The following is a description of a gene set: Human Gene Set: GSE37605_TREG_VS_TCONV_C57BL6_FOXP3_IRES_GFP_UP The aim of this study was to quantify the impact of chimeric Foxp3-GFP protein on the Treg cell transcriptional program. from publication Darce J, Rudra D, Li L, Nishio J, Cipolletta D, Rudensky AY, Mathis D, Benoist C (PMID 22579475) Genes up-regulated in splenocytes from Foxp3-ires-GFP B6 mice: T reg (FOXP3+) versus T conv (FOXP3-). species: Homo sapiens, and this is the list of marker genes: CFAP100, TRIM63, DPP10, KRT40, CRELD1, ACSBG1, FOXI3, P2RX5, CHRNG, CILP (NCBI Gene Id 8483), HAND1 (heart and neural crest derivatives expressed 1), NALF1, FTMT (NCBI Gene Id 94033), MBOAT4, HMG20B, FZD5, KRT33A, ATP2B3, SLC25A42, NMS, SLC16A8, TMEM169, NEUROD1, SPAG6, TSPOAP1, HAPLN3, CDV3, NDST3, SDR9C7, MFAP2, CLDN17, CRYGS, FOXF2, RSPO4, SLC8A3, SDCBP2, TMEM25, TMEM82, STK31, SLC2A6, TMEM17, SPHKAP, MAFA (MAF bZIP transcription factor A), KY, VMO1, FBP1, KRTAP11-1, CHMP6, YBX2, IFFO2, ISX, LINGO1, MAP3K21, LRIT3 (leucine rich repeat, Ig-like and transmembrane domains 3, NCBI Gene Id 345193), UTY, HTR6, RNASEH2C, SIX1, MAFF, CIMIP7, MYO16, ATP8B3, TSPYL5, CRMP1, ANKAR, TG, UNC5CL, OOEP, KRT24, FAM78B, CHGB, WIPF3, CRYM, SULT6B1, ABCC12, RUNDC3A, TM4SF5, PPP2R2C, RABGAP1L, ZKSCAN2, DNALI1, UNC45B, EDAR, CCKBR, RYR1, ADAM5, POMGNT2, SIX3, KRT72, ASCL2, CHRNA7, ENO4, GPR61, GALE, TBATA, CSRNP3, HOXD13, SPINK8, HMGA2, MMP7, SYT5, CACNA1C, ANKRD1, DYDC2, HSPA4, DIPK1B, PAK4, NPTX1, MYPN (myopalladin), TRIM29 (tripartite motif containing 29), FOXE1 (forkhead box E1), GAS8, IRX5, ATCAY, TRIOBP, SPEN, GRM4, LAMA3, ACTN3, PJVK, FOXN4, PLG, DIXDC1, CRPPA, TAC4 (tachykinin precursor 4), AK4